Given this list of marker genes Ednrb, Trpv1, Ccl5, Il1a, Ptgs2, Tnf, Ccr5, Ptges, Il1rn, Tnfsf11, Ptger3, Tnfrsf11a, Cnr1 (cannabinoid receptor 1), Il1b, here is a description of the gene set: Mouse Gene Set: GOBP_FEVER_GENERATION The heat generation process that results in a rise in body temperature above the normal, often as a response to infection. studied in species Mus musculus